The following is a description of a gene set: species: Homo sapiens Human Gene Set: MIR6515_5P Genes predicted to be targets of miRBase v22 microRNA hsa-miR-6515-5p in miRDB v6.0 with MirTarget v4 prediction scores > 80 (high confidence targets). from publication Chen Y, Wang X (PMID 31504780), and this is the list of marker genes: NBPF4, RHOBTB2, GSG1L, GAS7, ZBTB20, GZF1, SGSM1, STC1, ZNF750, SUPT4H1, GDF11, GABRA3, CDC27, ST3GAL1, CNNM3, TP53INP2, WIPF3, SYT1, NDUFC2-KCTD14, WNT2B, FAM177B, AK4, AKT1, TAPBP, ATRX, SCAI, CARM1, ACAN, S100A16, GFAP, DYRK2, FILIP1L (NCBI Gene Id 11259), NDUFA4, BCL9L, POU3F3, WAS, KCTD14, UBE4B, RBBP5, NFIC, CUX1, ZIC4, NIBAN3, STON2, SLC38A1, GPATCH2L (NCBI Gene Id 82392), PROCA1, FOXC1, CNTFR, FXN, XPO5, RBM18, USP9X, CAMK1D, FMNL3, TUBB, LPO, CYP2F1, VSTM2B, SERPINA6, TNFAIP8L3, RELCH (NCBI Gene Id 57614), CNTN2 (NCBI Gene Id 6900), MUC13, MTCL2, HSPA6, IL12RB2, COA8, PRRG3 (NCBI Gene Id 79057), RABGEF1, CALCR, TEKTL1, PIK3C2B, RNASEH2C, PKNOX2, TNFSF8 (TNF superfamily member 8), RORA, NOD1, ADIPOQ, UBE2D3 (NCBI Gene Id 7323), PARD3B, SMARCC2 (SWI/SNF related, matrix associated, actin dependent regulator of chromatin subfamily c member 2), SYP, LINC02693, RAB12 (NCBI Gene Id 201475), SLC41A1, ANKRD63, RAB11FIP5, TIMP2, CD200R1, HIP1, PAQR4